The following is a description of a gene set: Mouse Gene Set: HUMMERICH_SKIN_CANCER_PROGRESSION_UP Chemically induced mouse skin carcinogenesis represents the most extensively utilized animal model to unravel the multistage nature of tumour development and to design novel therapeutic concepts of human epithelial neoplasia. We combined this tumour model with comprehensive gene expression analysis and could identify a large set of novel tumour-associated genes that have not been associated with epithelial skin cancer development yet. Expression data of selected genes were confirmed by semiquantitative and quantitative RT-PCR as well as in situ hybridization and immunofluorescence analysis on mouse tumour sections. Enhanced expression of genes identified in our screen was also demonstrated in mouse keratinocyte cell lines that form tumours in vivo. Self-organizing map clustering was performed to identify different kinetics of gene expression and coregulation during skin cancer progression. Detailed analysis of differential expressed genes according to their functional annotation confirmed the involvement of several biological processes, such as regulation of cell cycle, apoptosis, extracellular proteolysis and cell adhesion, during skin malignancy. Finally, we detected high transcript levels of ANXA1, LCN2 and S100A8 as well as reduced levels for NDR2 protein in human skin tumour specimens demonstrating that tumour-associated genes identified in the chemically induced tumour model might be of great relevance for the understanding of human epithelial malignancies as well. from publication Hummerich L, Müller R, Hess J, Kokocinski F, Hahn M, Fürstenberger G, Mauch C, Lichter P, Angel P (PMID 16247483) Selected genes up-regulated during progression through benign to malignant skin tumors formed by treatment with DMBA and TPA chemicals in the two stage skin carcinogenesis model. studied in species Mus musculus, and this is the list of marker genes: Casp8, Il1rn, Serpinb1a, Rcan1, Cyba, Hspa8, Vcam1 (vascular cell adhesion molecule 1), Blmh, Mt1, Itga5, Sod2, Osbpl1a, Casp1, Uba3, Il17ra, Tnfrsf1a, Gadd45b, Hspa5, Prkcsh (NCBI Gene Id 19089), Gabrb3, Pgk1, Lgals9, Col6a3, Cdkn1a, Ctsd, Col1a2, Maoa, Col18a1, Arih2, Mif, Cd44, Slc26a4, Col5a2, Ccl6, Krt16, Cul4a, Ncf2, Rhoc, Ccnf, Fos, Tnfrsf12a, H2-Ab1, Thbs2, Socs1, Apoc2, Lcn2, Itgb1, Cpxm1, Hmox1, Plg, Stat3, Sspn, Rgs2, Lnx1, Crabp2, Thop1, S100a6, Smad1, Ifi203, Pycard, Eno1, Lgals7, Krt19, Myc, Gcgr, Col1a1, Tacstd2, Gltp, Mmp9, Mt2, Adam8, Bcl10, Junb, Il4ra, Itgb4, Apc, Gpihbp1, Perp, Saa1, Mmp13, Dok2, Rbms1, Ifitm3, Rin1, Ide, Epcam, Mmp14, Col7a1, Sprr2a1 (NCBI Gene Id 20755)